Given this list of marker genes ARFGEF1, ABTB2, CDH13, ADGRA2, SMARCA2, PRSS22, E2F2, SNX27, TMEM120B, GEMIN4, AGAP1, IFT81 (intraflagellar transport 81), DIRAS1, ZEB2, CPNE5, CERS2, here is a description of the gene set: Genes predicted to be targets of miRBase v22 microRNA hsa-miR-6089 in miRDB v6.0 with MirTarget v4 prediction scores > 80 (high confidence targets). Human Gene Set: MIR6089 from publication Chen Y, Wang X (PMID 31504780) species: Homo sapiens